Given this list of marker genes NOS1AP, CALM3, DYNLL1, ACTB, ESR1, ATP2B4, CAV1, HSP90AA1, NOS1, AKT1, NOS3, HSP90AB1, NOS2, here is a description of the gene set: studied in species Homo sapiens Human Gene Set: GOMF_NITRIC_OXIDE_SYNTHASE_ACTIVITY Catalysis of the reaction: L-arginine + n NADPH + n H+ + m O2 = citrulline + nitric oxide + n NADP+.